Given this list of marker genes Map2, Slc4a10, Mapk8 (NCBI Gene Id 26419), Nefh, Sh3gl2, Mirc35hg, Gata3un, Map1b, Slc17a8, Ykt6, Enpp1, Malat1, here is a description of the gene set: A dendrite that emerges near the basal pole of a neuron. In bipolar neurons, basal dendrites are either on the same side of the soma as the axon, or project toward the axon. Mouse Gene Set: GOCC_BASAL_DENDRITE studied in species Mus musculus